Given this list of marker genes Sfrp4, Cebpb, Slc34a1, Stc2, Cry2, Atf4, here is a description of the gene set: Mouse Gene Set: GOBP_REGULATION_OF_SODIUM_DEPENDENT_PHOSPHATE_TRANSPORT Any process that modulates the frequency, rate or extent of sodium-dependent phosphate transport. species: Mus musculus